Given this list of marker genes ALAD, PPOX, UROS, ALAS1, IREB2, UROD, CPOX, ALAS2, EIF2AK1, FECH, HMBS, here is a description of the gene set: species: Homo sapiens Human Gene Set: GOBP_PROTOPORPHYRINOGEN_IX_METABOLIC_PROCESS The chemical reactions and pathways involving protoporphyrinogen IX, the specific substrate for the enzyme ferrochelatase, which catalyzes the insertion of iron to form protoheme. It is probably also the substrate for chlorophyll formation.